Given this list of marker genes Fkbp1a, Lrg1, Smad2, Tgfb3, Snx6, Smad7, Eng, Fermt2, Tgfbr2, Snx25, Tgfb1, Smad6, here is a description of the gene set: species: Mus musculus Mouse Gene Set: GOMF_TYPE_I_TRANSFORMING_GROWTH_FACTOR_BETA_RECEPTOR_BINDING Binding to a type I transforming growth factor beta receptor.